Given this list of marker genes SMAD3, CCN2, MAPK1, LTBP1, ANGPT2, LTBP2, POSTN, FLNA, SHC1, TGFBR1, NR2C2, AGTR1, MAPK8, FBN2 (fibrillin 2), TGFBR2, ENG, TGFBR3, FBN3, FBN1, MAPK3, SMAD4, SMAD2, SERPINE1, RUNX2, MAPK14, here is a description of the gene set: Human Gene Set: WP_HYPOTHESIZED_PATHWAYS_IN_PATHOGENESIS_OF_CARDIOVASCULAR_DISEASE Hypothesized pathways in pathogenesis of cardiovascular disease species: Homo sapiens